Given this list of marker genes Naa10, Slf1, Nsmce2, Slf2, Smc5, Tnks (tankyrase, TRF1-interacting ankyrin-related ADP-ribose polymerase), Sgo2a, Atrx, Macroh2a1, Bub1, here is a description of the gene set: species: Mus musculus Mouse Gene Set: GOBP_REGULATION_OF_MAINTENANCE_OF_SISTER_CHROMATID_COHESION Any process that modulates the extent to which the association between sister chromatids of a replicated chromosome is maintained.